The following is a description of a gene set: Genes having at least one occurrence of the motif TGACAGTTTTAYGR in the regions spanning 4 kb centered on their transcription starting sites. This matches the MEIS1, HOXA9 transcription factor binding site V$MEIS1BHOXA9_01 (v7.4 TRANSFAC). Human Gene Set: MEIS1BHOXA9_01 species: Homo sapiens, and this is the list of marker genes: PCSK2, ADGRL2, DRD3, RTL10, ACAN, HOXC4, EBF2, UTY, TCF3, ARPC5, CDH13, DMD (NCBI Gene Id 548327), GBF1, HOXA6, SCML1, OTOP2, BAIAP2L1, IRX3, TFAP4, PDLIM1, NRP1, PHOX2B, PTH1R, HRK, HOXD9, AP3S1, HOXC12, FOXB1, EIF4ENIF1, CISH, NECAP1, ARF3, TTC12, HS3ST3A1, TPM2, TNFRSF8, ARL4C, RPLP0, ESRRG, OLFM1 (NCBI Gene Id 22825), SAMD11, RPP25, ZIC5 (Zic family member 5), RBBP8NL, FRMD6, LPAR1, SGIP1, PIK3CG, NPVF, CLPX, DNAJB7, HOXB7, HOXA11, KDM6A, ACTN2, AMOT, GNL2, NRAS, CHN2, KLRC2, ZMYND8, ZC3H18, SKAP1, ZBTB18, KCNV2, NMNAT2, PIK3R1, TBL1X, PATE2, ARMCX4, TBR1, LMO3, NR2F2, NFIL3, SYNPR, ZNF362, COPS3, NMNAT3, HIPK1, KLF14, GRM8, IL19, STEAP4, ITGB3BP, SOST, CHODL, GNAO1, MBNL1, NFKB2 (nuclear factor kappa B subunit 2), CRX, GABRG2, ZFHX3 (zinc finger homeobox 3), NOVA1, WNT6, DSPP, NHSL2, KLHL1, OTX2, MRPS18B, CNIH3, TLE4, TAFA1, ZIC4, CACNB3, ANKS1B, SIM1, KLRC3, RAB10, LARP4, KLHL4, TTF2, IRS1, NOG, PIANP, HNF4G, CYLD, RASGRF1, LONRF3, ADNP, ST8SIA2, ATP2B3, SLC44A1, MDK, MYO1C (NCBI Gene Id 4641), IL17A (interleukin 17A), UBR1, UNC5C, NIPBL, HOXC5, LINC01597, UNC79, INSM1, ATP13A4, FEZF2, GNB1L, WDR82, CD79B, GBX2, PPP1R10 (NCBI Gene Id 5514), CSMD3, TFDP2, PLEKHA6, CDK14, HOXA3, ATG12, USH1G